The following is a description of a gene set: Mouse Gene Set: BOYLAN_MULTIPLE_MYELOMA_C_UP from publication Boylan KL, Gosse MA, Staggs SE, Janz S, Grindle S, Kansas GS, Van Ness BG (PMID 17483317) Genes up-regulated in group C of tumors arising from overexpression of BCL2L1 and MYC in plasma cells. Multiple myeloma is an incurable plasma cell malignancy for which existing animal models are limited. We have previously shown that the targeted expression of the transgenes c-Myc and Bcl-X(L) in murine plasma cells produces malignancy that displays features of human myeloma, such as localization of tumor cells to the bone marrow and lytic bone lesions. We have isolated and characterized in vitro cultures and adoptive transfers of tumors from Bcl-xl/Myc transgenic mice. Tumors have a plasmablastic morphology and variable expression of CD138, CD45, CD38, and CD19. Spectral karyotyping analysis of metaphase chromosomes from primary tumor cell cultures shows that the Bcl-xl/Myc tumors contain a variety of chromosomal abnormalities, including trisomies, translocations, and deletions. The most frequently aberrant chromosomes are 12 and 16. Three sites for recurring translocations were also identified on chromosomes 4D, 12F, and 16C. Gene expression profiling was used to identify differences in gene expression between tumor cells and normal plasma cells (NPC) and to cluster the tumors into two groups (tumor groups C and D), with distinct gene expression profiles. Four hundred and ninety-five genes were significantly different between both tumor groups and NPCs, whereas genes were uniquely different from NPCs in tumor group C and genes were uniquely different from NPCs in tumor group D. Similar to human myeloma, the cyclin D genes are differentially dysregulated in the mouse tumor groups. These data suggest the Bcl-xl/Myc tumors are similar to a subset of plasmablastic human myelomas and provide insight into the specific genes and pathways underlying the human disease. species: Mus musculus, and this is the list of marker genes: Fam110a, Mcm3, Fkbp3, Clip1, Mtor (mechanistic target of rapamycin kinase), Arvcf, Dhx38, Ptgr1, Apobec2, Emid1, Fam13a, Prm1, Zbed4, Spinkl, Gm46430, Rbks, Lpcat1, Jcad, Fam53b, Dpp4, Tspyl3 (NCBI Gene Id 99345), Ets1, Pter, Cpsf6, Cad, Heatr1, Ppm1f, Asb2, Tyms, Dyrk2, Vpreb3, Smtnl2, Pde2a, Ebf1, Marcksl1, Angptl4, 1810059H22Rik, Rlim, Nasp, Stx2, Hnrnpd, Zmynd19, Cstf1 (NCBI Gene Id 99067), Zfpm1, Gas5, Spib, Lrig1, Lgr5, Foxp4, Nfya, Carmil1, Skp2